Given this list of marker genes PPP1R12A, CENPF, AP1S1, TTC7A, PI4KA, XIAP, ZNF699, MYCN, SLC25A12, RFX6, MIR17HG, here is a description of the gene set: species: Homo sapiens Abnormal jejunum morphology An abnormality of the jejunum, i.e., of the middle section of the small intestine. Human Gene Set: HP_ABNORMAL_JEJUNUM_MORPHOLOGY